The following is a description of a gene set: Neighborhood of PTPRB studied in species Homo sapiens Human Gene Set: MORF_PTPRB Neighborhood of PTPRB protein tyrosine phosphatase, receptor type, B in the MORF expression compendium, and this is the list of marker genes: R3HCC1L, BRWD1, HOXD13, AQP7, PTPN20, COLGALT2, COX6A2, SGCD, AMMECR1, COL19A1, FGF18, CLCN3, TPD52L1, ATF2 (NCBI Gene Id 1386), NFAT5, FLRT2, BMP10, CD8A, APOBEC1, ZNF202, EXOC4 (NCBI Gene Id 60412), LINC00588, SPA17, PPP2R5B, ADAM22, PDE10A, IFNA2, ITIH1, CTRL, GPR19, CDR1, CAMK4, PAX6, NDP (NCBI Gene Id 4693), TBXT, SLC26A4, CEP162, CALN1, CXCL5, PLA2R1, ITGA2, SERPINA4, MAGEA8, PART1, FGF9, PCM1, MDM2, HTR1E, OR10H3, WBP4, ZSCAN26, SULT4A1, FOSL1, MAP3K1, BRINP3, LGI1, AMOT, TBX19, FAS, SCN7A, LECT2, NPFF, ELAVL2, CFH, RREB1, ZNF141, FPR2, PDE4D, RUFY3, CMKLR2, KLRC4, H3C6, ABCB10, IL16, RORB, IGKV7-3, C1orf216 (chromosome 1 open reading frame 216), RPS6KA5, CACNA2D1, ZNF157, CYP2C19, OR2B6, F2RL3, GCA, CCR3, PPM1E, YLPM1, FGF2, IPO9 (NCBI Gene Id 55705), BICD1, ITIH3, EDIL3, SLC4A8, JRKL, IFNA8, IFNA1, SUPT3H, RB1CC1, CELA2B, SPATA2, ATP4B, CADM4, COL14A1, ABCC8, TANC2, ARL3, SMYD3, CDC73, NIPA2, KRT2, POU6F2, RXRG, ZNF132, NR3C2, MAP2, FNTB, PRKG1, MLLT10, TTN, JADE3, GNG4 (NCBI Gene Id 2786), MEOX2, COQ7, DAZL, GRIK1, HCRTR2, SLC33A1, SLC6A2, FRY, SIX6, EXOC6B, ADAM20, PTPRB, P2RY10, MYL3, DNAJC22, GYS2, SLC22A6, STAC (SH3 and cysteine rich domain), COL8A1, IL7, BCL2L11, MC5R, GPR171, ERC1, CPB2, TMEM26, KLHL23, GJB5, ZNF134, PIK3C2A, FBXL4, ZBTB40, TENM4, GCM1, KRR1, NEB, KNG1, GABRB2, TFDP2, LILRA1, PGM3, HSD3B2, AOC4P, SLC15A1, ZBTB33, DBT, ZBTB14, ABCB1, CCL16, MAGEA9, MYT1, DMD, TLL1, TRIM24, HEPH, ISL1, FSHR, ULK2, NTNG2, SIRPB1, ERCC4, DDX52, EYA1, ERC2-IT1, NRXN1, IL11RA, PKP1, PRKCA, PLPPR4, KRT34, NHEJ1, DRD1, TTTY1, TSSK2, GUCY2C, TPD52, ZNF33B, FAM110B, S100A5, CHRNB4, THPO (NCBI Gene Id 84434), LORICRIN, B4GALT6, PHF10, NR1I2, POLR1HASP, PRIM2, VSTM4, CPEB3, ADGRL2, PVR, ZNF266, RGS7, ZP2, ST8SIA1, PSG1, HRK, RAD51D, RYR3, ABO, KDR, SGPL1, POLR3F, POU6F1, GPR18, ADAMTSL3, GUCY2F, POLR2K, HSPA1L, GLRA3, IFNW1, EPHB2, HNF1A, RUNX2, SPRR2C, OCM, TPO, TSPAN2, PHLDB1, FUT1, SIM2 (SIM bHLH transcription factor 2), MSL3, GPLD1, ATXN3, LDB3, ATP8B1, OPLAH, FZD5, CYP2E1, IFNA10, PDE6A, FAM13A, PHOX2B